The following is a description of a gene set: studied in species Mus musculus The multiplication or reproduction of mammary gland epithelial cells, resulting in the expansion of a cell population. Mammary gland epithelial cells make up the covering of surfaces of the mammary gland. The mammary gland is a large compound sebaceous gland that in female mammals is modified to secrete milk. Mouse Gene Set: GOBP_MAMMARY_GLAND_EPITHELIAL_CELL_PROLIFERATION, and this is the list of marker genes: Btrc, Gpx1, Esr1, Robo1, Pygo2, Deaf1, Cebpb, Brca2 (breast cancer 2, early onset), Chuk (NCBI Gene Id 12675), Rreb1, Stat6, Gata3, Phb2, Zfas1, Tfap2c, Mapk1, Cdkn2a, Bax, Hoxa5, Wnt5a, Mst1, Rtn4, Med1, Zfp703, Agap2, Tnfsf11, Areg, Etv4, Id2, Ccnd1, Iqgap3, Epha2, Kdm5b